The following is a description of a gene set: studied in species Homo sapiens from publication Konuma T, Nakamura S, Miyagi S, Negishi M, Chiba T, Oguro H, Yuan J, Mochizuki-Kashio M, Ichikawa H, Miyoshi H, Vidal M, Iwama A (PMID 21540074) Each fraction of mouse hematopoietic cells was purified by cell sorting from bone marrow of 8-week-old C57BL/6 mice, and its gene expression was analyzed. Human Gene Set: GSE27786_NKCELL_VS_NEUTROPHIL_DN Genes down-regulated in comparison of NK cells versus neutrophils., and this is the list of marker genes: ARHGAP42, MCF2L, RANBP9, ADIPOR2, SLC28A2, AJM1, MINDY3, TIAM1, CBLN2, MED13L, GP9, MYMK, KCND1, EDNRA, LDHD, PPP1R3C, NGFR, BANK1, TDRD7, NPY, DCTN3, PDE6H, HOXD9, JPH3, PIWIL2, C5orf47, STMP1, NR3C1, CASK, ARMC7, RIGI, ATP8A2, D2HGDH, RDH11, STRA8, FTMT, SOX12, RNF125, AGFG1, NR1H2, PPP2CB, ZNRF1, SIGLEC10, ICAM5 (NCBI Gene Id 7087), HOXD4, RINL, TMX4, FBXO3, TEX35, CHRM3, DVL1, C21orf58, KLK10, RAB24 (RAB24, member RAS oncogene family), STK40, SMARCA1, GINM1, PIGU, AMOTL2, RAB3GAP2 (NCBI Gene Id 26114), LMAN2L, GSX2, ARPC1B, SIT1, ZNF516, GP1BA, CRY1, NISCH, TTLL3, DMTN, CA10, EMP3, KLHL2, SLC22A14, FBXL19, RAD52, PALM, RAB11B, SLC22A13, CLVS2, ME3, MYO3A, OSM, SYPL1 (synaptophysin like 1), ARMC3, GPR83, CLEC2L, MFSD4A (major facilitator superfamily domain containing 4A), OSBPL7, FDPS, GAPDHS, SLC17A9, SYT11, BOC, SF3B2, TAT, HACD4, BASP1, CFAP119, ZMYM2, COX19, RAD54B, GALE, GRIK2, INPP5K, JPH4, CDC42EP5, TEAD1, NDUFA1, SEMA3G, FUT7, UFD1, FA2H, SS18L2, C10orf90, SLITRK6, HLX, CRTC3, MUC4, CCDC62, NDUFA8, ITPRIPL2, NBEAL2, GALR2 (galanin receptor 2), LRRC8D, ACVR1C, CCDC126, FGF21, USP47, SPI1, UGDH, ADIPOR1, MBD2, TFAP2A, PRC1 (NCBI Gene Id 9055), VAV3, SFMBT2, DCAF12, PLEKHG3, RNF24, LRRC72, TCIM, PPP4R4, ARL2BP, ARHGAP30, MIEF2, TKFC, TRAPPC2L, DRC12, CACNG4, STK26, CCBE1, HIPK2, GREM2, PLK2, CCNDBP1, CCSER1 (coiled-coil serine rich protein 1), SSC5D (scavenger receptor cysteine rich family member with 5 domains), KLHL40, AQP12A, GGNBP2, ZXDC, SLC37A3, PPOX, NFASC, VILL, KDM6B, THSD4, HCK, ZG16, PITHD1, RGCC, TMC5 (transmembrane channel like 5), E2F8, STRADB, TTC32, SALL3, EML2, ATP6V1C2, FBXO42, CCN3, PNPLA7, CDX4, CPEB2, PRCD, SSC4D (NCBI Gene Id 136853), FDFT1 (NCBI Gene Id 2222), GALNS, ACTL7B, GNMT, ENPP2, TMEM104, ARPC2, PLEKHA2, RP2, SLCO3A1, ZNHIT1 (zinc finger HIT-type containing 1), BIN3 (NCBI Gene Id 55909), MINAR2, CDKN2A